The following is a description of a gene set: species: Homo sapiens A form of hypersociability that presents as mostly inappropriate friendliness towards others. Human Gene Set: HP_OVERFRIENDLINESS Overfriendliness, and this is the list of marker genes: DDX59, CLIP2, POGZ, SMARCA2, GTF2IRD1, TMEM270, EIF4H, BAZ1B, RFC2, GTF2IRD2, ELN, DNAJC30, CHAMP1, STX1A, LIMK1, KANSL1, FKBP6, METTL27, GTF2I, NCF1, BUD23, SRRM2, PIGH, MED13L, TBL2, VPS37D